Given this list of marker genes Nudt16, Kat2b, Cdkn2a, Rbm10, Pten, Malsu1, here is a description of the gene set: Mouse Gene Set: GOBP_NEGATIVE_REGULATION_OF_RIBOSOME_BIOGENESIS Any process that decreases the rate, frequency or extent of ribosome biogenesis. Ribosome biogenesis is the cellular process that results in the biosynthesis of constituent macromolecules, assembly, and arrangement of constituent parts of ribosome subunits. species: Mus musculus